Given this list of marker genes MAPK1, PTP4A1, PTP4A2, RABGGTB, BCAR1, ROCK1, CCNA2, ITGB1, ITGA1, CCNE1, EGR1, SRC, RABGGTA, RAC1, AGT, TUBA1B (NCBI Gene Id 88851), CDK2, ATF5, PTP4A3, RHOA, RHOC, MAPK3, CDKN1A, here is a description of the gene set: Human Gene Set: PID_PRL_SIGNALING_EVENTS_PATHWAY Signaling events mediated by PRL from publication Schaefer CF, Anthony K, Krupa S, Buchoff J, Day M, Hannay T, Buetow KH (PMID 18832364) species: Homo sapiens